The following is a description of a gene set: Human Gene Set: MIR455_3P studied in species Homo sapiens Genes predicted to be targets of miRBase v22 microRNA hsa-miR-455-3p in miRDB v6.0 with MirTarget v4 prediction scores > 80 (high confidence targets). from publication Chen Y, Wang X (PMID 31504780), and this is the list of marker genes: TPRG1, GLCCI1, POU3F3, MINDY1, DYNLL2, GNL1, COLEC12, SEMA3G, PACC1, EPHB1, FRMD3 (FERM domain containing 3), ARMC8, SSR1, RTN4, USP30, RUSC1, GABARAPL2, UBE2K, PTPN9, FXR1, HSF1, ZBTB18, HNRNPR, ACAN, PSIP1, SAR1A, KIF5A, PIK3R1, TMED7, CARF, TMEFF1, CUL3, STRADB, NLN, TFRC, TBC1D24, TTK, GPATCH2L, WDR26, NOL4, MSANTD3-TMEFF1, NR2F1, SALL1, NOVA1, BLTP3A, STK17B, KMT2C (NCBI Gene Id 80260), SEC62, TENM3, PDE4DIP, PRKAB2, SCG3, PRKD3, EID1, UBE2Q2, NFIB, SLC25A3, CD80, VEGFC, ID2, XCL1, HOXC4, BCL2L12, FRYL (FRY like transcription coactivator, NCBI Gene Id 728298), XCL2, KMT2A, ADCY1, XPO1, CLVS2, TENM4, FBXO42, RMND5A, PPP2CB, SLC22A4, FAM227A, OTOR, CNOT6, OTULINL, FZD10 (frizzled class receptor 10), PNPLA6, ZCCHC10, PHF6, GRAMD2B, MARVELD3, LCE6A, MFAP3L, TPT1, ZFP36L1, GTPBP1, SLC35F1, ACP2, ELF3